The following is a description of a gene set: Human Gene Set: GOCC_LATE_ENDOSOME_MEMBRANE The lipid bilayer surrounding a late endosome. species: Homo sapiens, and this is the list of marker genes: ATP13A3, MARCHF1, LAMP3, ATP10B, OSBPL9, PLD1, SLC9A9, STARD3NL, GIMAP5, IFITM2 (NCBI Gene Id 10581), HLA-DQB1, PLEKHM1, VAMP8, WDR91, LAPTM4A, SLC39A14, RHOB, CHMP2A, ANXA8, CLN3, VPS33A, SNX16, IFITM3, HLA-DPB1, SLC38A9, GOSR2, VPS37B, ANXA2, KCNK6, VPS4B (NCBI Gene Id 9525), HGS, ABCB6, PLD3, VPS39, LITAFD, SLC11A1, VTI1B, HLA-DMB, SNF8, ADAM30, CLCN3, RAB7A, UBXN6, ANXA6, CHMP3, SLC1A1, SORL1, TMEM30A, LAMTOR3, ATP13A4, VAC14, VPS37A, VAMP7, STOML1, BAIAP3, CHMP4A (charged multivesicular body protein 4A), MITD1, CHMP2B (charged multivesicular body protein 2B), HLA-DRB1, ELAPOR1, YIPF1, CD300LG, ATP9A, VPS37C, CHMP4B, CHMP4C, MAPKAP1, TSG101, NPC1, SLC31A1, FIG4, LAMTOR1, TMEM9, CD68, NSG1, MVB12B, STARD3 (StAR related lipid transfer domain containing 3), NOTCH1 (NCBI Gene Id 54781), B2M, VPS11, ARL8A, VPS36, WDR81 (NCBI Gene Id 780925), SLC11A2, PIKFYVE, ATP13A2, MICALL1, RNF13, LITAF, ABCA5, RAB27A, SLC30A3, LAPTM4B, MCOLN1 (mucolipin TRP cation channel 1), AP5M1, VPS33B, CHMP4BP1, SPPL2A, HLA-DOA, RILP, OSBPL11, RAB27B, YIPF2, TMEM163, VPS16, GALNTL5, LAMP2, SLC9A8, CHMP6, SLC29A3, HLA-DQB2, MARCHF8, NSG2, VPS28, CYB561A3, SCARB2, VPS13C, ATP13A5, CHMP7, IRGM, SLC9A6, VPS37D, RAB7B, ARL8B, AP5S1, ENTREP1, ABHD6, TSPAN15, GPR65, SNX14, ABCA3, ATG9A, VPS18, MR1, MREG (melanoregulin), HLA-DRA, LAMTOR5, MCOLN2, CHMP1B (charged multivesicular body protein 1B), HLA-DRB4 (major histocompatibility complex, class II, DR beta 4), LAMP5 (lysosomal associated membrane protein family member 5), TMEM106B, CLCN6, SLC31A2, HLA-DOB, NDFIP2, LAMP1, PIP4P1, LAMTOR2, VTI1A, CD63, MTMR4 (NCBI Gene Id 9110), RMC1, HLA-DQA2, ZMPSTE24, HLA-DMA, PMEL, MVB12A, SLC30A4, TMEM59, HLA-DPA1, VPS41, NTRK1, HLA-DRB5, HLA-DRB3, CDIP1, HLA-DQA1, TPCN2, VOPP1, TICAM2, CHMP1A, LAMTOR4, VPS4A, CLCN4, SPAAR, PIP4P2, MMD, CHMP5, MCOLN3